The following is a description of a gene set: To discover novel metastasis suppressor genes that are clinically relevant in common human cancers, we used isogenic human bladder cancer cell lines and used DNA microarray technology to identify genes whose expression diminishes as a function of invasive and metastatic competence. We then evaluated the expression profile of such genes in 105 pathologically characterized tumors from seven common organ sites, and we identified one gene, RhoGDI2, whose expression was diminished as a function of primary tumor stage and grade. When RhoGDI2 was transferred back into cells with metastatic ability that lacked its expression, it suppressed experimental lung metastasis but did not affect in vitro growth, colony formation, or in vivo tumorigenicity. In addition, RhoGDI2 reconstitution in these cells blocked invasion in an organotypic assay and led to a reduction of in vitro motility. These results indicate that RhoGDI2 is a metastasis suppressor gene, a marker of aggressive human cancer, and a promising target for therapy. Human Gene Set: GILDEA_METASTASIS from publication Gildea JJ, Seraj MJ, Oxford G, Harding MA, Hampton GM, Moskaluk CA, Frierson HF, Conaway MR, Theodorescu D (PMID 12438227) studied in species Homo sapiens Top genes down-regulated in metastatic (T24T) vs non-metastatic (T24) bladder cancer cell lines., and this is the list of marker genes: IGFBP5, PTX3, MYL9, KRT19, SLC2A10, RAC2, FN1, TACSTD2, IFI16, SPARC, ARHGDIB, TAGLN, ADIRF, GLIPR1, GBP1, BST2, SMARCA4 (NCBI Gene Id 6597), MPZL2, CAVIN3, DUSP4, IGFBP4, TIMP3, VAMP5, HNMT, CPQ, SRGN, IFI27, COL5A2, AKR1C3